Given this list of marker genes Mgst1, Prkd1, Cd36, Trp53inp1, Tmigd1 (transmembrane and immunoglobulin domain containing 1), Sin3a, Oxr1, Dapk1, Ddias, Prkcd, here is a description of the gene set: studied in species Mus musculus Any process that results in a change in state or activity of a cell (in terms of movement, secretion, enzyme production, gene expression, etc.) as a result of a hydroperoxide stimulus. Hydroperoxides are monosubstitution products of hydrogen peroxide, HOOH. Mouse Gene Set: GOBP_CELLULAR_RESPONSE_TO_HYDROPEROXIDE